Given this list of marker genes BMP2, EXT1, RFLNB, DCHS1, CCDC154, XYLT1 (xylosyltransferase 1), LTF, RFLNA, ADAMTS7, FGFR3, THBS3, PAX2, SNX10, PHOSPHO1, RYR1, RET, ZBTB16, IGF1 (insulin like growth factor 1), LEP, GH1, GREM1, SEMA4D, ALDH1A2, GATA3, IFT80, ACTN3, PTH, ADAMTS12, RHOA (ras homolog family member A), MBTPS2, EBP, PLXNB1, here is a description of the gene set: studied in species Homo sapiens A developmental process, independent of morphogenetic (shape) change, that is required for an animal organ to attain its fully functional state. An organ is a tissue or set of tissues that work together to perform a specific function or functions. Human Gene Set: GOBP_ANIMAL_ORGAN_MATURATION